Given this list of marker genes LRRC14, SVOP, MRPL46, DNAJC21, CES5A, GFM1, MECR, STT3B, EIF2B1, USP22, MRPL47, NDUFB9, KLHL40, KCNJ8, MPPED2, TTLL5, NSUN4, UNC13A, DTNBP1, STRAP, SLX4, AMDHD2, MAPK4, PCGF2, GDI2, PAQR4, METTL13, POPDC2, MAPK1IP1L, CEP44 (centrosomal protein 44), BHLHE40, DDX11, GPRIN2, SEC14L2, ELAVL1, TMEM50B, MINPP1, LIAS, SRPX2, WARS1, ISCA2, HARBI1, CNIH3, PRSS8, NSFL1C, ELK1, OXSR1, ABCB10, GAL, CSF2RA, CUL4A, ZSWIM7 (zinc finger SWIM-type containing 7), C12orf56, EIF1, CD44, ACLY, BLOC1S2, NELFCD (NCBI Gene Id 51497), QSOX2, GIPC2, KCTD11, TUBB2B, ADAT1, CRTAP, SEC61A2, INSRR, EDC3 (enhancer of mRNA decapping 3), NUDCD2 (NCBI Gene Id 134492), INSYN2A, GRHL2, MUTYH, UBQLN4, STN1, SCFD2, TMEM165, CRIP2, ATP5F1A (ATP synthase F1 subunit alpha), RGMB, POLR2E, TPPP, SYNGR1, FANCB, GPR179, RIOX1, KLC1, METTL2B, GEMIN7, PRDX3, STON1, BICD2, BBS10, RPL23A, CCNC (cyclin C), HMGA1, MAP9, PDIK1L, LRWD1, ESCO2, NEDD8, STRADB, GCHFR, ZNF580, EXOC3L4, THAP4, QTRT2, LMAN1, ZNF239, PSMB4, HSPA4L, OPN1SW, PDCD2, UFM1, SANBR, SWI5 (NCBI Gene Id 375757), RBM10, MFN2, YIF1A, NGFR, CLNS1A, TMEM106C, SLC6A6, TKFC, ST3GAL4, GID8, PPIP5K1, IL20, PECR, PPP1R3C, ARHGAP22, ENC1, MTLN, STX12, CRELD1, RCAN1 (regulator of calcineurin 1), FAM229B, SUCLG1, NEURL1B, EIF2B4, MRPL14, YWHAG, SF3A1, LHX2, VSIG2, GDAP1L1, MIR22HG, ZW10, PTK2, DGAT2, C3, ACAA2, SEM1, RPAIN, SERPINC1, SLC39A1, CALU, ZFAT, BOP1, EVPL, SAMM50, SLC22A15, ZNF446, SLFN12, C10orf88, CASP7, CNOT8, MEAK7, ATG13, P2RX1, FZD4, TSTD2, ERC1, ATP5MC2, CLK3, DNAJC12, BGN, TMEM70, EEF1AKMT1, PTHLH, NSUN2, KIF18A, RAD1, PTPRJ, GADL1, NFKBIL1, PRM2, SNRPF, C11orf71, C9orf72, ADIPOR2, MSH6, DIABLO, SNRPD2, NDE1, IFT27, NUP58, SLC9A5, UBD, ATP6V0D1, CCNK, TAF12, here is a description of the gene set: Genes up-regulated in comparison of induced regulatory T cell (Treg) versus natural regulatory T cell (Treg). from publication Wei G, Wei L, Zhu J, Zang C, Hu-Li J, Yao Z, Cui K, Kanno Y, Roh TY, Watford WT, Schones DE, Peng W, Sun HW, Paul WE, O'Shea JJ, Zhao K (PMID 19144320) Multipotential naïve CD4+ T cells differentiate into distinct lineages including T helper 1 (Th1), Th2, Th17, and inducible T regulatory (iTreg) cells. The remarkable diversity of CD4+ T cells begs the question whether the observed changes reflect terminal differentiation with heritable epigenetic modifications or plasticity in T cell responses. We generated genome-wide histone H3 lysine 4 (H3K4) and lysine 27 (H3K27) trimethylation maps in naïve, Th1, Th2, Th17, iTreg, and natural (n)Treg cells. We found that although modifications of signature cytokine genes (Ifng, Il4, and Il17) partially conform to the expectation of lineage commitment, critical transcription factors such as Tbx21 exhibit a broad spectrum of epigenetic states, consistent with our demonstration of T-bet and IFN-gamma induction in nTreg cells. Our data suggest an epigenetic mechanism underlying the specificity and plasticity of effector and regulatory T cells and also provide a framework for understanding complexity of CD4+ T helper cell differentiation. studied in species Homo sapiens Human Gene Set: GSE14308_INDUCED_VS_NATURAL_TREG_UP